The following is a description of a gene set: We found that a number of Tfh cells downmodulated BCL6 protein after their development, and we sought to compare the gene expression between BCL6-hi Tfh cells and BCL6-low Tfh cells. Genes up-regulated in BCL6 high follicular helper T cells versus naïve T CD4 cells. from publication Kitano M, Moriyama S, Ando Y, Hikida M, Mori Y, Kurosaki T, Okada T (PMID 21636294) Human Gene Set: GSE24574_BCL6_HIGH_TFH_VS_NAIVE_CD4_TCELL_UP studied in species Homo sapiens, and this is the list of marker genes: PIAS3, FLOT2, JUNB, CTSH, PADI2, TRAF3IP2, THBD, XDH, CHRDL1, MMP3, KCNJ12, BLM, DNAJB2, FOXO4, RGS1 (NCBI Gene Id 5996), RRP8, CTSK, GPSM2, PLD3, KCTD2, RASA3, FAM161A, MYOC, ERC1, FXYD3, KAT2A, PIM1 (NCBI Gene Id 82453), HDAC6, TREX1, PLA2G6, ABR, FCHO1, UBA7, FNTB, ADRA1A, ACAA1, KDELR3, MAP3K9, PER1, ZMYM3, PLXNB3, SIT1, CCR8, THEMIS2, CPB1, MT2A, ABCC10 (NCBI Gene Id 89845), ID2, PRKACG, PDE6B, PIEZO1, TXNIP, H2AC17, TNFAIP3, MYH11, H4C2, LTA4H, PHKG2, RBM38, TPM2, SEC14L2, SMR3B, ICAM3, PARN, SPDEF, RPS14, PLIN1, LTB4R, GUCA2A, DHCR7, IL11RA, LRCH1, ITGA2B, CXCL12, CAPN1, DIO2, MUC1 (mucin 1, cell surface associated), NCKIPSD, MFGE8, NBAS, TSN, TKT, SIRPA, EN2, TFAP4, SC5D, ITIH4, KAT7, CDH2, DNM3, OR2B6, PCBP3, CD300C, TAOK3, H1-4, TPX2, EDN2, ZNF500, ADCY9, ALDH2, TRIB2, UQCR11, DNAJB1, LPAR2, MICA, AIF1, FGFR1, IFIH1, ZNF101, KRT20, SCN7A, INS, OXT, TBC1D9B, PIM2, GABARAPL1, GPC4, CCDC57, DGCR2, NAGLU, MED24, CA11, ULK2, GLYAT, NCAPD2, THRA, VPS11, EIF3G, TRANK1, SPP2, ITGB2, ESR1, BTF3P12, MAN2B2, CIZ1, FLRT1, IRF3, CCT6B, AIP, ASIC1, ARID4B, TAFAZZIN, CXCR6, SEC31B, BMPR1B, PPP2R5D, MAP4K2, H2BC10, PRDM1, SIK1, INSL4, MAPK3, TYR, PPEF2, PFKL, NPY2R, GATAD1, CTSW, SIGLEC6, ZBTB25 (zinc finger and BTB domain containing 25, NCBI Gene Id 7597), IMPDH1, PYGM, TMSB10, CXCR4, CDH22, SLC29A2, KLF5, CDC25B, SOX4, MFNG, HDGF, GRHPR, PAPSS2, GYPB, AUH, PRG4, PDCL, CPZ, RECQL5, HPGD, MYL2, OPRK1, CDH3, GPI, MPZL1, FCHSD2, RALYL, GUCY2F, ACR, DDIT3, PCDH7, CECR7, RPL14, PLA2G4C, WWOX, PIP4K2B (NCBI Gene Id 8396), HIPK2